The following is a description of a gene set: Citron kinase (CIT) or citron RHO-interacting kinase (CRIK) shares similarities with ROCK kinases. Like ROCK, it consists of a serine/threonine kinase domain, a coiled-coil region, a RHO-binding domain, a cysteine rich region and a plekstrin homology (PH) domain, but additionally features a proline-rich region and a PDZ-binding domain. A shorter splicing isoform of CIT, citron-N, is specifically expressed in the nervous system and lacks the kinase domain. Citron-N is a component of the post-synaptic density, where it binds to the PDZ domains of the scaffolding protein PDS-95/SAP90.<p>While the binding of CIT to RHO GTPases RHOA, RHOB, RHOC and RAC1 is well established, the mechanism of CIT activation by GTP-bound RHO GTPases has not been elucidated. There are indications that CIT may be activated through autophosphorylation in the presence of active forms of RHO GTPases (Di Cunto et al. 1998). CIT appears to phosphorylate the myosin regulatory light chain (MRLC), the only substrate identified to date, on the same residues that are phosphorylated by ROCKs, but it has not been established yet how this relates to activation by RHO GTPases. CIT and RHOA are implicated to act together in Golgi apparatus organization through regulation of the actin cytoskeleton. CIT is also involved in the regulation of cytokinesis through its interaction with KIF14 and p27(Kip1). part of: RHO GTPase Effectors Reactome Pathway: RHO GTPases activate CIT studied in species Homo sapiens, and this is the list of marker genes: PPP1CB, MYL9, MYL6, RAC1 (Rac family small GTPase 1), MYH14, CDKN1B, DLG4, CIT, PPP1R12A, MYH9, MYL12B, KIF14, RHOC, PRC1, RHOB, MYH11, PPP1R12B, RHOA, MYH10